The following is a description of a gene set: Human Gene Set: GOMF_GLUTAMATE_RECEPTOR_ACTIVITY Combining with glutamate and transmitting the signal from one side of the membrane to the other to initiate a change in cell activity. species: Homo sapiens, and this is the list of marker genes: GRIA2, GRM6, GRM8, GRID2, GRIN1, GRIK3 (glutamate ionotropic receptor kainate type subunit 3), GRM4 (NCBI Gene Id 2914), GRIA3, GRIN2C, GRIA4, GRIN2D, GRIK1, GRM3, GRM2, GRIN3B, GRID1, GRIA1, GRIN2B, GRIK2, GRIN2A, GRIK4, GRM1, GRM5, GRIN3A, GRM7, GRIK5